The following is a description of a gene set: Human Gene Set: HP_GLIOMA The presence of a glioma, which is a neoplasm of the central nervous system originating from a glial cell (astrocytes or oligodendrocytes). Glioma studied in species Homo sapiens, and this is the list of marker genes: IDH2, CDKN2B, SPRED1, SETBP1 (SET binding protein 1), POLE, POLD1, ZFTA, ATM, KRIT1, MSH2, BMPR1A, KRAS, CCM2, BRCA2, MSH6, MEN1, TGFBR2, EPCAM, MLH1, TSC2, FGFR1, SMO, SEMA4A, MDM2, CDKN2A, NSD1, MSH3, PTEN, NF1, IFNG, ERBB2, TSC1 (NCBI Gene Id 7248), CDKN1B, APC2, CDKN2C, PDCD10, CDKN1A, PMS1, RPS20, APC, NF2, NBN, MUTYH, IDH1, PMS2, PIK3CA, TP53, CHEK2